Given this list of marker genes NLRP7P1, STX16-NPEPL1, TFF1, LNCATV, TDRD3 (tudor domain containing 3), STARD10, PABPC1, ENSG00000254337, NONO, STX16, GREB1, LINC00963, CARM1, FKBP4, here is a description of the gene set: Genes containing one or more binding sites for (CARM1) in their promoter regions (TSS -1000,+100 bp) as identified by GTRD version 20.06 ChIP-seq harmonization. Human Gene Set: CARM1_TARGET_GENES from publication Yevshin I, Sharipov R, Kolmykov S, Kondrakhin Y, Kolpakov F (PMID 30445619) species: Homo sapiens